Given this list of marker genes CDH23, KCNJ11, CDKN1B, LIPA (lipase A, lysosomal acid type), PEX6, LHX4, MRPS25, ARMC5, KDM1A, WT1, TXNRD2, PEX1, CYP11B2, GNAS, GMPPA (GDP-mannose pyrophosphorylase A), CDKN1A, STEAP3, PEX26, CTNNB1, NDUFAF5, MKRN3, NR5A1, NR0B1, SRY, SOX9, CUL3, KANSL1, TBX19, CYP21A2, GATA4, NFKB2 (nuclear factor kappa B subunit 2), CYP11A1, PEX13, AIRE, SNRPN, BRAF, WWOX, SNORD115-1, PWRN1, HSD3B2, PROP1, CYP17A1, SAMD9 (NCBI Gene Id 54809), RET, POMC, BCOR, ZNRF3, NFS1, VAMP7, MAP3K1, PDE8B, HBB, PEX3, PCSK1, MCM4 (NCBI Gene Id 780917), GK, PRNP, PWAR1, TERT, TBCK, PEX5, WNK1, IARS2, NNT, SGPL1, PEX10, HTR1A, MYT1L, NDN, GPR101, RBM28, OCA2 (OCA2 melanosomal transmembrane protein), CDKN2B, PEX2, TRAPPC11, GLI3, TCTN3, HSD17B4, NPAP1, MRAP, POR, WNK4, MRPS7 (NCBI Gene Id 64967), PEX11B, USP8, ZFPM2, NR3C2, MC2R, PEX12, AIP, PEX14, SAA1, HERC2, PEX19, SCNN1A, PRKAR1A, NR3C1, STAR (NCBI Gene Id 6770), USP48, SNORD116-1, MEN1, CDKN2A, AAAS, CYP11B1, PEX16, ATRX, CDKN2C, TP53, KLHL3, PRKACA (protein kinase cAMP-activated catalytic subunit alpha), PDE11A, MAGEL2, DHX37, ABCD1, here is a description of the gene set: Human Gene Set: HP_ABNORMALITY_OF_ADRENAL_PHYSIOLOGY studied in species Homo sapiens Abnormality of adrenal physiology A functional abnormality of the adrenal glands.